The following is a description of a gene set: Abstract: Trastuzumab-induced cardiotoxicity (TIC) is a common and serious disease with abnormal cardiac function. Accumulating evidence has indicated certain non-coding RNAs (ncRNAs), functioning as competing endogenous RNAs (ceRNAs), impacting the progression of cardiovascular diseases. Nonetheless, the specific involvement of ncRNA-mediated ceRNA regulatory mechanisms in TIC remains elusive. The present research aims to comprehensively investigate changes in the expressions of all ncRNA using whole-transcriptome RNA sequencing. The sequencing analysis unveiled significant dysregulation, identifying a total of 43 circular RNAs (circRNAs), 270 long noncoding RNAs (lncRNAs), 12 microRNAs (miRNAs), and 4131 mRNAs in trastuzumab-treated mouse hearts. Subsequently, circRNA-based ceRNA networks consisting of 82 nodes and 91 edges, as well as lncRNA-based ceRNA networks comprising 111 nodes and 112 edges, were constructed. Using the CytoNCA plugin, pivotal genes - miR-31-5p and miR-644-5p - were identified within these networks, exhibiting potential relevance in TIC treatment. Additionally, KEGG and GO analyses were conducted to explore the functional pathways associated with the genes within the ceRNA networks. The outcomes of the predicted ceRNAs and bioinformatics analyses elucidated the plausible involvement of ncRNAs in TIC pathogenesis. This insight contributes to a better understanding of underlying mechanisms and aids in identifying promising targets for effective prevention and treatment strategies. studied in species Mus musculus Mouse Gene Set: XIE_TRASTUZUMAB_CARDIOTOXICITY_MMU_MIR_483_5P_GENES from publication Xie S, Zhou N, Su N, Xiao Z, Wei S, Yang Y, Liu J, Li W, Zhang B (PMID 38577019), and this is the list of marker genes: Afg3l1, Celf1, Foxp4, Pygo2, Mapk8ip3, Bcl9l, Hlcs, Tbc1d14, Slc25a51, Snrk (NCBI Gene Id 97116)